Given this list of marker genes AASS, MYH7, MGP, NKX2-6, TBX1, MMP21, CCDC22, TRAIP, PLXND1, ALDH1A2, here is a description of the gene set: Underdevelopment of the pulmonary artery. species: Homo sapiens Human Gene Set: HP_PULMONARY_ARTERY_HYPOPLASIA Pulmonary artery hypoplasia